Given this list of marker genes FSHB, CACNA1H, BMP2, REST, STARD3, DAB2, BMP6 (NCBI Gene Id 7964), WNT4, CYP11B1 (NCBI Gene Id 1584), EGR1, CYP11B2, CYP11A1, TSPO, SCP2, DKK3, ADM, DGKQ, BMP5, CLCN2, AKR1B1, LHB, here is a description of the gene set: Human Gene Set: GOBP_C21_STEROID_HORMONE_BIOSYNTHETIC_PROCESS studied in species Homo sapiens The chemical reactions and pathways resulting in the formation of C21-steroid hormones, steroid compounds containing 21 carbons which function as hormones.